Given this list of marker genes PHGDH, TYMS, PSPH, PSAT1, SHMT2, SRR, DHFR (NCBI Gene Id 203373), SHMT1, here is a description of the gene set: Serine metabolism Human Gene Set: WP_SERINE_METABOLISM species: Homo sapiens